Given this list of marker genes FGF5, FGF4, FGF6, FGF8, FGFR1, FGF1, FGF20 (fibroblast growth factor 20), FGF9, FGF2, FGF17, FGF23 (NCBI Gene Id 8074), here is a description of the gene set: Reactome Pathway: Signaling by activated point mutants of FGFR1 part of: FGFR1 mutant receptor activation Unlike FGFR2 and FGFR3, FGFR1 appears not to be a frequent target of activating point mutations. Germline point mutations at residue P252 have been identified in Pfeiffer syndrome while mutation of the same residue arising somatically has been identified in melanoma and lung cancer. Two kinase domain mutations have been characterized in glioblastoma, both at positions that are also mutated in an autosomal disorder in one of the FGFR family members. species: Homo sapiens